The following is a description of a gene set: Human Gene Set: HP_BRUXISM species: Homo sapiens Bruxism Bruxism is characterized by the grinding of the teeth including the clenching of the jaw and typically occur during sleep, but also can occur while the affected individual is awake., and this is the list of marker genes: H4C5, MECP2, FOXG1, AFF3, NTNG2, HNRNPK, AHDC1, CAMK2B, CRELD1, PGAP3, ATG7, MYT1L, SPTBN1, PTRHD1, CACNA1B, PUS7, ADNP, KIF15, RHOBTB2, GNB2, CACNA2D1, ANK3, EEF1A2, GABBR2, DHX30, ITPR1, ZBTB18, ZEB2, PDE2A, MBD5, VPS13A, CERT1 (NCBI Gene Id 10087), ZFX, TRAPPC9, CDKL5, NEXMIF, HTT (NCBI Gene Id 3064), SHANK3, GRIN1